Given this list of marker genes Dync2i2, Nudcd3, Dync1i1, Dnah10, Dynlt4, Dynlt2a1, Dnali1, Dnah7b, Dnah11, Dnai7, Dync2li1, Dnah6, Dnal1, Dnah1, Dnah3, Dnah17, Dynlrb1, Dynlt5, Dnal4, Dnah12, Dnai1, Dnah2, Dnah7a, Dynlt1a, Dynlt1c, Tpr, Dync2h1, Dnai3, Dync1h1, Drc1, Dync1i2, Dync1li2, Dnah5, Dynlt2b, Nme8, Dynlrb2 (dynein light chain roadblock-type 2), Odad1, Dnai2, Cfap70, Dynlt3, Dynlt1f, Dnah8, Dnah9 (dynein, axonemal, heavy chain 9), Disc1, Dnah14, Dynll2 (dynein light chain LC8-type 2), Dync1li1, Dctn1, Dctn2, Dnah7c, Dnai4, Dync2i1, Dynlt1b, Dnhd1, Ccdc65, Dynll1, Snx4, Dctn4, Ccdc103, BC048507, here is a description of the gene set: species: Mus musculus Mouse Gene Set: GOCC_DYNEIN_COMPLEX Any of several large complexes that contain two or three dynein heavy chains and several light chains, and have microtubule motor activity.